Given this list of marker genes TGFB3, MORC2, ADAMTS15, ADAT3, PIEZO2, COL12A1, CAPN3, SCN4A, PRG4, KCNK9, FBN2, here is a description of the gene set: species: Homo sapiens Congenital finger flexion contractures Multiple bent (flexed) finger joints that cannot be straightened actively or passively. Human Gene Set: HP_CONGENITAL_FINGER_FLEXION_CONTRACTURES